Given this list of marker genes Ext1, Ptger4, Inpp4b, Gpr137b, Tns3, Vegfa, Mdk, Trf, Idua, Fshb, P3h4, Itgb3, Lrp5, Tnfrsf11b, Ccdc154, Slc4a2, Tnfrsf11a, Siglec15, Traf6, Nox4, Gja1, Lep, Lgr4, Ptn, Src, Il7, Tmem64, Ptk2b, Adam8, Rassf2, Efna2, Ctnnb1, Il6, Oscar, Ahsg, Itgav, Cartpt, Herc1, Rac1, Dock5, Inpp5d, Def8, Il20ra, Egfr, Mc4r, Wnt16, Ncdn, Adrb2, Fshr, Tpp1, Pth1r, Notch2, Rab7, Hamp, P2rx7, Fgfr3, Fcgr4, Ihh, Tmem119, Spp2, Arap1, Tcirg1, Acp5, Plekhm1, Lrrk1, Rac2, Gsk3b, Cbl (NCBI Gene Id 12402, Casitas B-lineage lymphoma), Rufy4, Spp1, Cldn18, Rab3d, Gpr137, Grem1, Pdk4, Sfrp1, Ubash3b, Snx10, Car2, Tfrc, Ctss, Lrp6, Dlk1, Enpp1, Tph1, Ppargc1b, Csk, Cd38, Syk, Cyp19a1, Nf1, Prkca, Calcr, Bbln, Iapp, Cthrc1, Lepr, Gdf5, Htr1b, Hnf1a, Csf1r, Epha2, Suco, Syt7, Ltbp3, Dcstamp, Ctsk (cathepsin K), Tnfsf11, Mitf, S1pr1, Ceacam1, Gpr55, Slc34a1, here is a description of the gene set: The continuous turnover of bone matrix and mineral that involves first, an increase in resorption (osteoclastic activity) and later, reactive bone formation (osteoblastic activity). The process of bone remodeling takes place in the adult skeleton at discrete foci. The process ensures the mechanical integrity of the skeleton throughout life and plays an important role in calcium homeostasis. An imbalance in the regulation of bone resorption and bone formation results in many of the metabolic bone diseases, such as osteoporosis. Mouse Gene Set: GOBP_BONE_REMODELING species: Mus musculus